The following is a description of a gene set: Genes up-regulated in comparison of systemic lupus erythematosus CD4 T cells versus systemic lupus erythematosus myeloid cells. Human Gene Set: GSE10325_LUPUS_CD4_TCELL_VS_LUPUS_MYELOID_UP studied in species Homo sapiens from publication Hutcheson J, Scatizzi JC, Siddiqui AM, Haines GK 3rd, Wu T, Li QZ, Davis LS, Mohan C, Perlman H (PMID 18275831) Gene expression profile studies have identified an interferon signature in whole blood or mononuclear cell samples from patients with systemic lupus erythematosus. This study was designed to determine whether specific lymphocyte and myeloid subsets freshly isolated from the blood of systemic lupus erythematosus patients demonstrated unique gene expression profiles compared to subsets isolated from healthy controls., and this is the list of marker genes: DYRK2 (dual specificity tyrosine phosphorylation regulated kinase 2), LCK, SOD1, ST13, PHC1, PEBP1, LDLRAP1, ABLIM1, PIK3IP1 (NCBI Gene Id 113791), BCL2 (NCBI Gene Id 596), TUT4, KLHL3, BCL11B, ACAP1, AKT3, IL16, JADE2, GATA3, TXK, MPI, MLLT11, SPTBN1, RPSA, SLC35E2B, TMEM204, TRAF5, DEXI, ITM2A, TRIB2, ITPR3, ZNF32, HMOX2, MAGED1, PJA1, SEPTIN6, SLC25A38, SRSF8, PTPRCAP, RPL35, RANGRF, AP3M2, CBX7, TCF7, NPM1, PRKD2, CEP68, GIMAP5, BACH2, PRKACB, SIGIRR, UBASH3A, RAPGEF6, DIPK1A, AQP3, DPP4, CD2, FLT3LG, ANKRD28, CAD, ZNF512B (NCBI Gene Id 57473), CTC1, PBXIP1, MAST4, SH3YL1, ITGA6, GOLGA8B, PPP1R16B, FHIT, GNB5, MAN1C1, PKIA, STAT5B (NCBI Gene Id 6777), CHMP7, ATF7IP2, ARID5B, TGFBR3, CDR2, DENND2D, MLLT3, FAM171A1, USP20, SYNRG, CLEC2D, NAE1, ATIC, GSPT2, RIOX1, ANK3, SNRPD2, SINHCAF, C10orf95-AS1, CCT4, CD28, S1PR1, PRPS1, CD247, GRAP2, FHL1, P4HTM, FKBP11, IL2RG, B3GNT2, KIF21B, FBL, ZAP70, RHOH, PLCG1, RHOF, RPS10P5, PIM2, SLC38A1, GOLGA8A, TESPA1, PLEKHB1, DOCK9, ZBTB25, GPX7, REXO2, EPHX2, GPA33, ICOS, SYNE2, PURA, NPRL2, ASNS, CD6 (CD6 molecule), RPL10A, CD3D, CD27, HINT1, RETREG1, TRAC, PRKCQ, MYBL1, HIVEP2, GARRE1, ZMYND11, LTB, CD3G, PASK, UBE2D2, SKAP1, CD96, HMCES, NELL2, FOXO1, IL32, EIF4A2, KLRB1, FASN, NOSIP, RASGRP1, TATDN2, DPH5, CBR3, ATP2A3, LEF1, TRBC1, ECHDC2, OXCT1, MAL, ZSCAN18, CCND2, BEX3, GCC2, TRAV8-3, SPOCK2, PSIP1, NCK2, EEIG1, PTPN4, SIDT1, EVL, SLAMF1, ITK, TRADD, GPR171, PPP3CC, TNFRSF25, GPRASP1, LTBP3, ST6GAL1, IL2RB, XPC, DNAJC9 (DnaJ heat shock protein family (Hsp40) member C9), STAT4, PRKCA, LY9, GTF3A (general transcription factor IIIA), PDCD4, PRORP, SIT1, FCMR, NCL, PRKCH, LBH, LDHB, TBC1D4, CDC25B